The following is a description of a gene set: Tight junctions (TJs) are the most apical component of the epithelial junctional complex forming a belt-like structure at the cellular junction. When visualized by freeze-fracture electron microscopy they appear as a branched network of intramembrane strands that correspond to the sites of direct membrane contacts and that are composed of the integral membrane claudin proteins. The TJs act as a primary barrier to the diffusion of solutes through the paracellular space (barrier function). They also prevent the intermixing of intramembrane proteins and lipids and thus create a boundary between the apical and the basolateral membrane domains of polarized epithelial cells (fence function). Interestingly, the fence function seems not to depend on TJ strands. Recents evidence indicates that the TJs also participate in signal transduction mechanisms which regulate cell proliferation and morphogenesis. This module describes the major molecular interactions responsible for the formation of TJ strands and for the rectruitment of the PAR-3-PKC-PAR-6 and CRB3-Pals1-PATJ complexes that function in tight junction formation. Reactome Pathway: Tight junction interactions studied in species Homo sapiens part of: Cell-cell junction organization, and this is the list of marker genes: CLDN22, CRB3, PARD6A, CLDN7, CLDN20, PARD6B (NCBI Gene Id 84612), CLDN18, CLDN14, F11R, CLDN12, CLDN5, PARD3 (NCBI Gene Id 56288), CLDN9, CLDN8, CLDN6, CLDN1, CLDN10, PATJ, CLDN15, CLDN11, PARD6G, CLDN2, CLDN4 (claudin 4), CLDN19 (NCBI Gene Id 30063), PALS1, PRKCI, CLDN16, E, CLDN17, CLDN23, CLDN3